The following is a description of a gene set: Binding to a dynactin complex; a large protein complex that activates dynein-based motor activity. studied in species Mus musculus Mouse Gene Set: GOMF_DYNACTIN_BINDING, and this is the list of marker genes: Snx6, Hook3 (hook microtubule tethering protein 3), Gsk3b, Snx5, Sptbn5, Bicdl1, Bicd1, Bicd2, Htt, Bbs4